Given this list of marker genes Cog3, Cog5, Cog4, Tmem115, Cog7, Cog8, Cog6, Cdc42, Cog1, Cog2 (component of oligomeric golgi complex 2), here is a description of the gene set: studied in species Mus musculus A multisubunit tethering complex of the CATCHR family (complexes associated with tethering containing helical rods) that has a role in tethering vesicles to the Golgi prior to fusion. Composed of 8 subunits COG1-8. Mouse Gene Set: GOCC_GOLGI_TRANSPORT_COMPLEX